The following is a description of a gene set: Human infertility and recurrent pregnancy loss caused by implantation defects are poorly understood. Hoxa-10-deficient female mice have severe infertility and recurrent pregnancy loss due to defective uterine implantation. Gene expression profiling experiments reveal that Hoxa-10 is an important regulator of two critical events in implantation: stromal cell proliferation and local immunosuppression. At the time of implantation, Hoxa-10 mediates the progesterone-stimulated proliferation of uterine stromal cells. Hoxa-10 mutants express a stromal cell proliferation defect that is accompanied by quantitative or spatial alterations in the expression of two cyclin-dependent kinase inhibitor genes, p57 and p15. Hoxa-10 deficiency also leads to a severe local immunological disturbance, characterized by a polyclonal proliferation of T cells, that occurs in place of the normal progesterone-mediated immunosuppression in the periimplantation uterus. Human Gene Set: YAO_TEMPORAL_RESPONSE_TO_PROGESTERONE_CLUSTER_11 Genes co-regulated in uterus during a time course response to progesterone: SOM cluster 11. species: Mus musculus from publication Yao MW, Lim H, Schust DJ, Choe SE, Farago A, Ding Y, Michaud S, Church GM, Maas RL (PMID 12554760), and this is the list of marker genes: IPO7, PUS1, GNL3, RANGRF, AARS1 (alanyl-tRNA synthetase 1), SEPTIN4, PNO1, DDX51, STIP1, KPNA2, METTL1, PELO, HDC, NOP56, NDUFAF4, FOXK2, AREG, NIFK, LTV1, UBQLN1, CRELD2, MAK16, NOP58, TARS1, ABCE1, FARSB, CLCN5, SYNPO, DNAJB11, PLA2G10, NPL, DDX21, LRP2, PSME3, DUS1L, NCBP1, HNRNPLL, ACTL6A, KRAS, HSPA5, GSPT1, GLI1, RIPOR2, BECN1, BYSL, MANF, SRM, IL13RA2, SLC35B1, HSP90B1, MYRF, EPB41, ACOT7, MRTO4, OLFM1, SRSF2, MARS1, EPRS1, USP39 (ubiquitin specific peptidase 39), STRAP, LGALSL, GMPPB, BOP1, TMEM9B, PPAN, SEC23B, LRRC59, HIF1A (hypoxia inducible factor 1 subunit alpha), PA2G4, CYCS, XPNPEP1, STX12, TFRC, SRRT, IGF1, PUM3, AMD1, HOMER2, NUCB2, SRSF3, UTP4, ALDH1A2, PDIA6, ADH5, CDO1, TIMM8A, GSTM5, RRAGA, FTSJ3, RRS1, CSE1L, CAD, TNFRSF21, TUBB2A, TSR1, PEX11A, AK6, BMS1, SELENOS, RDX